Given this list of marker genes POLR2E, ST6GALNAC4, SSRP1, ZNF580, CD3E, CDC37, NADSYN1 (NAD synthetase 1), RNPS1, R3HCC1, LIMD2, MYH9, HNRNPR, TP53, LIMK1, CFL1, CNOT3, PDIA3, ATP5MC2, ATP5F1E, PPP1R14B, MAP2K2, SSBP3, UBE2S, HMOX1, SMARCD2, SAC3D1, FAM53B, ERP29, TSR3, BBLN, PCBP1, NONO, NDUFS8, SF3B4, SRP14, PDAP1, DGKZ, CDCA4, NDUFC1, OSTF1, HRAS, NUTF2, SMIM10L1, ATP5F1D, APRT, SNRPF, AHCY, WDR45, LRRC47, ILVBL, XAB2, HNRNPK, SART1, DOK2, EIF3F, PKN1, FCHO1, CHCHD3, PTPRCAP, THOC6, VPS51, HSPA9, GATAD2A, ID2, BTF3, SRSF9, SUMO3, DDX49 (NCBI Gene Id 54701), FBXL15, ADA2, ZNF512B, SF3A2, PMS2P2, PFDN2, MFSD10, MINK1, SAFB, RNF19B, HMG20B, TNFRSF14, MSN, RAB5C, EDF1, DRAP1 (DR1 associated protein 1), HSF1, ECSIT, ANXA6, MTA1, HNRNPUL1, MARCKSL1, GTF2F1, RPLP2, CALM3, MVP, ERH, MT1X, SEC61G, CCDC22 (NCBI Gene Id 28952), MDH2, ILKAP, GID8 (NCBI Gene Id 54994), PTBP1 (polypyrimidine tract binding protein 1), U2AF2, REX1BD, GSN, LTBP4, SLC25A1, SLC52A2, FOXK2, RDH14, STK25, MEAF6, SNF8, UCP2, TRAPPC2, FXYD5, YBX1, WDR18, BCL7C, SAFB2, MRPS15, NDRG2, GLUD1, MCUR1, MRPL12, DEAF1, PRCC, MYG1, SH3GLB2, RPN1, BICRAL, TAF10 (NCBI Gene Id 6881), BECN1, CCDC85B, ELOC, ARPC4, GZMM, COTL1, RALY, ADRM1, SRRM1, EDEM2, ELF4, UQCRB, TGFB1, ATP1B3, CD81, RASGRP2, DBI, COX5A, TMED9, LSM12, HNRNPM, SFPQ, CBX4, TKT, PRPF31 (pre-mRNA processing factor 31), PAK2, PSMB10, CFDP1, FBXO41, HNRNPU, AP5Z1, PDLIM2, DAZAP1, NSMF, ATP5MC3, IDS, ADNP2, TLE5, RPL37 (ribosomal protein L37), TSPAN14, ARHGEF1, COPG1, IDUA, NDUFB8, NAA60, LPCAT4, ATP5ME, HLA-DPA1, PBX2, COPS7B, EIF4H, RBCK1, PFN1, PABPN1, RBM3, SPCS3, STARD3, PDIA4, CAPN15, SSH1, SERPINF1, CORO1B, MFNG, VPS4A, DNAJC7, RNF126, AURKAIP1, GPS2, here is a description of the gene set: Objective: We hypothesized that type 1 diabetes (T1D) is accompanied by changes in gene expression in peripheral blood mononuclear cells (PBMCs) due to dysregulation of adaptive and innate immunity, counterregulatory responses to immune dysregulation, insulin deficiency and hyperglycemia. Research Design and Methods: Microarray analysis was performed on PBMCs from 43 patients with newly diagnosed T1D, 12 patients with newly diagnosed type 2 diabetes (T2D) and 24 healthy controls. One and four month follow-up samples were obtained from 20 of the T1D patients. Results: Microarray analysis identified genes differing in expression between newlydiagnosed T1D patients and controls at a false discovery rate of 0.05. Changes in expression of interleukin-1β (IL1B), early growth response gene 3 (EGR3), and prostaglandin-endoperoxide synthase 2 (PTGS2) resolved within four months of insulin therapy and were also observed in T2D suggesting that they resulted from hyperglycemia. With use of a knowledge base, 81/genes could be placed within a network of interrelated genes with predicted functions including apoptosis and cell proliferation. IL1B and the MYC oncogene were the most highly-connected genes in the network. IL1B was highly overexpressed in both T1D and T2D, whereas MYC was dysregulated only in T1D. Conclusion: T1D and T2D likely share a final common pathway for beta cell dysfunction that includes secretion of interleukin-1β and prostaglandins by immune effector cells, exacerbating existing beta cell dysfunction, and causing further hyperglycemia. The results identify several targets for disease-modifying therapy of diabetes and potential biomarkers for monitoring treatment efficacy. Human Gene Set: GSE9006_HEALTHY_VS_TYPE_2_DIABETES_PBMC_AT_DX_UP from publication Kaizer EC, Glaser CL, Chaussabel D, Banchereau J, Pascual V, White PC (PMID 17595242) Genes up-regulated in comparison of peripheral blood mononuclear cells (PBMC) from healthy donors versus PBMCs from patients with type 2 diabetes at the time of diagnosis. studied in species Homo sapiens